Given this list of marker genes PHLDB1, PRR23B, MBTD1 (mbt domain containing 1), TMEM234, TCEANC2, MKI67, FNBP1L, RMND5A, PFN2, DNM1L, FAAP20, VIPR2, LZTS3, ORAI2, CAMK1D, STX1A, KCTD2 (NCBI Gene Id 23510), FAM53C, XPO7, ZHX2, ELL2, SLC10A3, NUDC, IVD, MSANTD1, RHOA, RORC, RBBP5, PITPNC1, PEX10, OPTC, INPP5J, CFL2, RAB7A, CSNK1G1, NFATC1, METTL8, ZC3H7B, KATNB1, CAPN6 (NCBI Gene Id 827), TMEM38A, ANKRD11, PPP1R12A, SERF2, EFTUD2, PDZD7, CBX7, XRN1, SPTBN2, POU2F2, ACTA1, PRP4K, SPATA12, LRRC27, FSHB, PALM2AKAP2, PPP1R9B, CREB1, PRR11, FBXO11, HDLBP, PRLR, SUGP2, RNF41, FAM78A, SLC10A1, CNGA2, BTN2A1, DSC3, RBP1, KDM3B, NOCT, FNBP1, EPHA4, PTEN, DNAJB12, NCK1 (NCBI Gene Id 4690), SENP1 (NCBI Gene Id 29843), GABBR2, CASTOR3P, PACS1, CYB561D1, MACROD2, FMNL3, LIMD2, RASSF8, TPD52L1, SUSD6, HK1, RAP2C, PPM1A, TRIM7, KLF9, FOSL1, PLXNA4, NOS1, OSER1, PIK3R5 (NCBI Gene Id 23533), SHB, RAB37, DSG1, GIPC3, KCTD5, TTC21B, WNT4, here is a description of the gene set: from publication Chen Y, Wang X (PMID 31504780) studied in species Homo sapiens Genes predicted to be targets of miRBase v22 microRNA hsa-miR-3135b in miRDB v6.0 with MirTarget v4 prediction scores > 80 (high confidence targets). Human Gene Set: MIR3135B